The following is a description of a gene set: Mouse orthologs of human prostate cancer tumor markers which were deregulated in mice heterozygotic for both NKX3.1 and PTEN. To identify biomarkers that discriminate the aggressive forms of prostate cancer, we performed gene expression profiling of prostate tumors using a genetically engineered mouse model that recapitulates the stages of human prostate cancer, namely Nkx3.1; Pten mutant mice. We observed a significant deregulation of the epidermal growth factor and mitogen-activated protein kinase (MAPK) signaling pathways, as well as their major downstream effectors--the activator protein-1 transcription factors c-Fos and c-Jun. Forced expression of c-Fos and c-Jun in prostate cancer cells promotes tumorigenicity and results in activation of extracellular signal-regulated kinase (Erk) MAPK signaling. In human prostate cancer, up-regulation of c-Fos and c-Jun proteins occurs in advanced disease and is correlated with Erk MAPK pathway activation, whereas high levels of c-Jun expression are associated with disease recurrence. Our analyses reveal a hitherto unappreciated role for AP-1 transcription factors in prostate cancer progression and identify c-Jun as a marker of high-risk prostate cancer. This study provides a striking example of how accurate mouse models can provide insights on molecular processes involved in progression and recurrence of human cancer. studied in species Mus musculus from publication Ouyang X, Jessen WJ, Al-Ahmadie H, Serio AM, Lin Y, Shih WJ, Reuter VE, Scardino PT, Shen MM, Aronow BJ, Vickers AJ, Gerald WL, Abate-Shen C (PMID 18381418) Human Gene Set: OUYANG_PROSTATE_CANCER_MARKERS, and this is the list of marker genes: AMACR, TFF3, KLK1, CCNE1, E2F4, CDKN1A, MTA1, FN1, CLU, ETS1, AR, EZH2 (NCBI Gene Id 392834), CTSB, IGFBP2, VAV3 (vav guanine nucleotide exchange factor 3), BCL2, CEACAM1, MET, MKI67, HPN, INSR